Given this list of marker genes ISY1, SIRT7, DGUOK, ARRDC1, ZNF593, IL15RA, RASA2, S100A9, PEX14, VAMP8, ATP10A, CCDC6, VDAC2, CRKL, NKIRAS2, EFNB3, ACOT8, SYTL4, ATG9B, HSDL2, GPS2, EFNB2, ACADL, RELL1, OXCT1, KLRK1, MSLN, SYS1, TRIM15, ST6GALNAC1 (NCBI Gene Id 55808), GGH, VPS26C, GBX2, IQSEC1, CDKN1A, RHOC, AUH, ANKRD44, PARP2, COL5A2, PRPSAP1, ZFP36L1, ZNF790, EPSTI1, S100A10, TAX1BP3 (Tax1 binding protein 3), MOV10, SNN, GFRA3, LRRK1, TIMM10B, PLD3, GSAP, RASGRP4, MLXIP, SAMD11, NFIL3, CTCF, GOT1, ADA, RBM43, NFIX, TNFRSF1A, FABP3, NDST1, SESN3, TLE2, PLEKHB2, MMP11, UBE2V1, TECPR1, SLC4A8, ADD3, PRR14, ZNF768 (NCBI Gene Id 79724), MRPS21, MICAL1 (NCBI Gene Id 64780, microtubule associated monooxygenase, calponin and LIM domain containing 1), NGRN, IRF2, RHOV, MOCS2, SLC25A22, AIDA, ZC3H18, THEMIS2, PTPRN2, AMACR, PYROXD1, RNASET2, NEDD4L, SHARPIN, MPP1, WNT10B, USF2 (NCBI Gene Id 7392), CSNK1G2, UBE2D1, ACTB, RNPEP, PDLIM4, RBKS, RNF44, PDPK1, UBD, AFF1, CEACAM21, ELANE, PIP5KL1, RPL13A, PABPC1, ZKSCAN3, NAGLU, THRAP3, MARCKS, CNPPD1, CAMKK2, UBE2L6, PHF5A, ZNF524, MERTK, ST14, TMEM131, CBX6, DNMT3A, SCAND1, NRG3, SLAMF8, MFAP1, PRDM9, PTN, TMEM219, DPCD, ANGEL2, CSPP1, MOB1B, OGFOD3, RBM42, SULT1B1, COX4I1, DNAJC12, SERHL2, BCL9, PLGRKT, CHMP4B, SAV1, LYL1, CACNG2, RNF181, NRDE2, PEX13, PPARGC1B, CIITA, DBNDD2, PTGDR2, PSMB6 (NCBI Gene Id 95505), PDCD6, ERF, CDX4, ARMCX5, TTLL3, P2RY14, GTF2H2, RREB1 (ras responsive element binding protein 1), TAF7, GJB5, CNOT6L, VPS18, FGF19, SUB1, MATN2, DKK2, EXOC6, TNFRSF11A (TNF receptor superfamily member 11a), TRAF2, PDCD1, SCN3A, CLIC4 (NCBI Gene Id 25932), EIF4E3, SPTLC2, CLASP2, CHRD, DAPP1, SLC22A23, PLAAT3 (NCBI Gene Id 11145), HTR3B, NTF3, HEBP1, SLFN12, COL4A4, NDUFB11, NSG2, TAT, GUK1, ANKRD22, SECISBP2, MYL12B, CLEC5A, LMX1A (NCBI Gene Id 4009), MAP3K14, here is a description of the gene set: from publication Amit I, Garber M, Chevrier N, Leite AP, Donner Y, Eisenhaure T, Guttman M, Grenier JK, Li W, Zuk O, Schubert LA, Birditt B, Shay T, Goren A, Zhang X, Smith Z, Deering R, McDonald RC, Cabili M, Bernstein BE, Rinn JL, Meissner A, Root DE, Hacohen N, Regev A (PMID 19729616) studied in species Homo sapiens Human Gene Set: GSE17721_POLYIC_VS_CPG_24H_BMDC_UP mouse primary BMDCs were stimulated with tlr ligands and gene expression changes were profiled on Affymetrix arrays Genes up-regulated in comparison of dendritic cells (DC) stimulated with poly(I:C) (TLR3 agonist) at 24 h versus DC cells stimulated with CpG DNA (TLR9 agonist) at 24 h.